The following is a description of a gene set: Human Gene Set: GSE31082_DN_VS_CD8_SP_THYMOCYTE_UP species: Homo sapiens Genes up-regulated in comparison of CD4- CD8- thymocytes versus CD4- CD8+ thymocytes. from publication Egawa T, Littman DR (PMID 21873191) Mouse thymocytes can be classified into four major subsets based on expression of CD4 and CD8 co-receptors. CD4-CD8- (double negative, DN) cells become CD4+CD8+ (double positive, DP) cells following productive T cell receptor (TCR) beta chain rearrangement. A small proportion of DP cells are selected through interaction of clonal TCRalpha/beta and MHC self peptide complex expressed on thymic stromal cells. DP cell expressing MHC class I-restricted TCR become CD4-CD8+ cells, which will finally differentiate into cytotoxic T cells, while MHC class II restricted selection generates CD4+CD8- helper lineage T cells. We used microarrays to identify genes important for thymocyte differentiation and lineage determination by profiling gene expression in different thymocyte subsets., and this is the list of marker genes: DAZAP1, CCDC40, SVIL, DIPK1B, GET1, ATAD3A, RTN4, ATP5F1B, TMEM170B, FASTKD2, ADK, CENPH, TMPO, UBA6, RPGR, TRIM24, UCHL3, GLT8D1, TTC7B, ILF2, AMZ2, IDE, HAUS5, TXNL1, PTRH2, POLA1, RSL1D1, GNAI3, STX12, GFI1, PARD6G, NUP93, PMM1, DTYMK, HBS1L, SART3, EXOSC9, KANSL1L, TMEM69, DDX20, SLC25A10, NCAPG2, ZNF667, ANKRD28, ARPC1A, ABHD17C, MRPS28, HSPA13, HNRNPM, SPEF1 (NCBI Gene Id 25876), ANO6, HMBS, STON1, SSR3, SLC35E3, ANAPC5, STOML2, MVK, ASRGL1, YAE1, TSEN2, OXR1, UTP11, ZNF229, TELO2, PGLS, JDP2, CINP (cyclin dependent kinase 2 interacting protein), PFAS, PBK, YWHAE, TAOK3, PREPL, SERPINE2, SLC25A15, GTF2H3, GTF2E2, PRICKLE1, UQCC6, RUVBL1, TSR2, PREP, ERCC6L2 (NCBI Gene Id 56959), PSMD1, ALDH9A1, SLC25A13, SNRPF, RGS12, LIG1, P2RY10, NUP155, DDX54, BID, DTX4, BCL7A, AHCTF1, H2AZ1, MGAT4B, RFC4, SRSF10, ORC6, FDFT1, MTRES1, DHRS3, GINS2, IPMK, CLCN2, TSPAN6, PSMD2, JADE3 (jade family PHD finger 3), FABP5, MSH6, DHDDS, ETF1, KYAT3, OBI1, MAGOHB, CSNK1E, GINS1, AATF, DDX21 (DExD-box helicase 21), MCM5, SLC7A1, E2F3, RBM12, SLF1, FADS2, TMEM106C, KPNA3, KAT14 (NCBI Gene Id 96680), PFKL, EIF2S1, IPO4, DHRS7B (NCBI Gene Id 82068), CST3, APPBP2, PTAR1, POLR3H, CEP70, ANKRD26, HAX1, BCAT1, PHF5A, PTBP2, TRIM44, PPIH, RAB1A, AKT1, NADK2, NDUFAB1, SWAP70, CENPO, MND1, PDF, MATCAP2, ETFB, TEX30, SNRPD1, CNIH1, RMDN3, GALK1, C1QBP, TMEM132A, KREMEN1, RNPS1, EHD4, RPRD1A, PRPS2, SLC25A51, MYBL2, SRM, COQ7, DHRS13, GLT8D2, CLSPN, NIFK, MED23, UQCC2, SNRPA, ABCB7, EXO1, TRAPPC13, ACLY (ATP citrate lyase), CPSF6, IFT22, UBE2Q2, FBXO45, PSMD12, POMT1, RCC2, PHF10, LYAR, FAM133B, SEH1L, HMGCS1, NHERF4, YARS1, BIVM, RAD50, TCEAL9